Given this list of marker genes Pdgfra, Nrp1, Pdgfrb, Bmp4, Notch2, Notch3, Tcf21, Pkd2, here is a description of the gene set: Mouse Gene Set: GOBP_RENAL_SYSTEM_VASCULATURE_MORPHOGENESIS studied in species Mus musculus The process in which the renal system vasculature is generated and organized. Morphogenesis pertains to the creation of form.